Given this list of marker genes ASL, ASS1 (NCBI Gene Id 445), CLN3, NAGS, OTC, here is a description of the gene set: studied in species Homo sapiens Human Gene Set: GOBP_L_ARGININE_BIOSYNTHETIC_PROCESS The chemical reactions and pathways resulting in the formation of arginine, 2-amino-5-(carbamimidamido)pentanoic acid.